The following is a description of a gene set: from publication Chen Y, Wang X (PMID 31504780) Genes predicted to be targets of miRBase v22 microRNA mmu_miR_465a_3p, mmu_miR_465b_3p, mmu_miR_465c_3p in miRDB v6.0 with MirTarget v4 prediction scores > 80 (high confidence targets). Mouse Gene Set: MIR_465A_3P_MIR_465B_3P_MIR_465C_3P species: Mus musculus, and this is the list of marker genes: Casp14, Actr3, Supt5, Ms4a5, Wfdc8, Smco1 (NCBI Gene Id 69576), Cd38, AA414768, Ect2, Dmtf1l, Cd300lb, Mrpl35, Ccdc88a, Hoxd3, Tlcd5, Prr15l, Trappc9, Zfp277, Nms, Piwil2, Col11a2, Abcc9, Pikfyve